The following is a description of a gene set: Purine ribonucleoside monophosphate biosynthesis Human Gene Set: REACTOME_PURINE_RIBONUCLEOSIDE_MONOPHOSPHATE_BIOSYNTHESIS species: Homo sapiens, and this is the list of marker genes: ADSS2, PAICS, ATIC, PFAS, GART, PPAT, ADSS1, ADSL, IMPDH1, GMPS, IMPDH2